Given this list of marker genes Lcn2, S100a9, Gtf2h5, S100a8, Wfdc21, here is a description of the gene set: species: Mus musculus Mouse Gene Set: TABULA_MURIS_SENIS_MARROW_BASOPHIL_AGEING from publication Tabula Muris Consortium (PMID 32669714)